The following is a description of a gene set: Ovarian infertility species: Mus musculus Mouse Gene Set: WP_OVARIAN_INFERTILITY, and this is the list of marker genes: Ptger2, Vdr, Esr2, Prlr, Atm, Dmc1, Ncor1, Nr5a1, Gdf9, Tbp (TATA box binding protein), Syne2, Inha, Zp2, Mlh1, Smpd1, Gja4, Cdkn1b, Fshr, Bmpr1b, Nrip1, Ccnd2, Msh5, Cebpb, Cyp19a1, Smad3 (SMAD family member 3), Egr1, Pgr, Lhcgr, Zp3, Dazl